The following is a description of a gene set: studied in species Homo sapiens Genes containing one or more binding sites for (ZNF501) in their promoter regions (TSS -1000,+100 bp) as identified by GTRD version 20.06 ChIP-seq harmonization. from publication Yevshin I, Sharipov R, Kolmykov S, Kondrakhin Y, Kolpakov F (PMID 30445619) Human Gene Set: ZNF501_TARGET_GENES, and this is the list of marker genes: SLC15A4, TCF12, NSMAF, WDR36, CMC1 (C-X9-C motif containing 1), IMPA2, GSTCD, EXOSC3, ZNF280D, ZNF775, INTS12, REPIN1, ZDHHC17